Given this list of marker genes CYRIA, BTRC, CLASP1, ZC3H6, PAK1, PNISR, SORCS1, NUMB, NR2C2, CROT, ELOVL7, ANKRD13A, ARK2C, KIAA1549, BASP1, ORC4, CFAP44, PUM2, TLK1 (NCBI Gene Id 9874), B3GALT2, ZNF277 (NCBI Gene Id 11179), MSTN, GPD1L (glycerol-3-phosphate dehydrogenase 1 like), PLEKHG7, CERT1, ELF5, KCNA4, ADAMTS9, LYPLA1, CLOCK, SETD7, ATP6V1G3, FBXW7, DNAJC22, B3GALNT1, KNSTRN, MTPN, TAF7L, MOB4, RBM27, ABCD3, GXYLT1, TRHDE, RASSF3, WEE1, ARMC8, RYBP, MEIS1, TCF21 (NCBI Gene Id 6943), CRLF3, RBM24, ASH1L (ASH1 like histone lysine methyltransferase), LRIT1, ZNF423, SCIMP (NCBI Gene Id 388325), NAV1, ETFA, DMXL1, ARID5B, MBNL1, LGALSL, RGS17, GATM, ELF2, NPAS3, FOXO1, TCHHL1, KIAA0825, SDK1, LIN7C, GTF3C3 (general transcription factor IIIC subunit 3), BICRAL, SDR16C5, ROR1 (NCBI Gene Id 4919), VLDLR, HOMER1, GFRAL, ZBTB18, LCLAT1, STRBP, KCTD10, OSBPL2, B4GALT5, DCAF13, CCNA2, ADAM9, PPP2R2C, RECK, GSTM3, ATP6V1A, here is a description of the gene set: from publication Chen Y, Wang X (PMID 31504780) Genes predicted to be targets of miRBase v22 microRNA hsa-miR-4445-5p in miRDB v6.0 with MirTarget v4 prediction scores > 80 (high confidence targets). Human Gene Set: MIR4445_5P species: Homo sapiens